The following is a description of a gene set: Human Gene Set: GOMF_CATALYTIC_ACTIVITY_ACTING_ON_A_RRNA species: Homo sapiens Catalytic activity that acts to modify a ribosomal RNA., and this is the list of marker genes: MRM1, FDXACB1, TFB2M, NSUN5, EMG1, TRMT2B, NOP2 (NCBI Gene Id 4839), METTL15, ZCCHC4, FBL, DIMT1, TSR3, BUD23, MRM3, FTSJ3, SPOUT1, TFB1M, METTL15P1, METTL25B, METTL5 (NCBI Gene Id 29081), FBLL1, MRM2, TRMT61B, NSUN4